Given this list of marker genes CHMP3, CHMP5, CEP97, HSPA1B, CHMP4BP1, CHMP4B, HSPA1A, CHMP4A (charged multivesicular body protein 4A), EML3, CHMP4C, CHMP7, RIPOR2, RCC1, HNRNPU, CCSAP, PLK1, CHMP1A, PDCD6IP, CHMP1B, CHMP2B, CHMP2A, DRG1, VPS4B, TPR, CHMP6, here is a description of the gene set: Any process that modulates the frequency, rate or extent of mitotic spindle assembly. Human Gene Set: GOBP_REGULATION_OF_MITOTIC_SPINDLE_ASSEMBLY studied in species Homo sapiens